The following is a description of a gene set: The aggregation, arrangement and bonding together of respiratory enzyme complexes I, III and IV of the mitochondrial inner membrane to form a large supercomplex. Mouse Gene Set: GOBP_MITOCHONDRIAL_RESPIRASOME_ASSEMBLY studied in species Mus musculus, and this is the list of marker genes: Higd1c, Higd1b, Higd1a, Cox7a1, Cox7a2l, Higd2a, Cox7a2, Rab5if, Stmp1